The following is a description of a gene set: Human Gene Set: FAN_EMBRYONIC_CTX_IN_3_INTERNEURON from publication Fan X, Dong J, Zhong S, Wei Y, Wu Q, Yan L, Yong J, Sun L, Wang X, Zhao Y, Wang W, Yan J, Wang X, Qiao J, Tang F (PMID 29867213) species: Homo sapiens, and this is the list of marker genes: PDE4DIP, MAF, ERBB4, LHX6, GAD1, BOD1L1